Given this list of marker genes CALM3, PPP3CC, PPP3R1, CALM2, TFEB, PPP3R2, MCOLN1, CALM1, PPP3CA, PPP3CB, here is a description of the gene set: Human Gene Set: KEGG_MEDICUS_REFERENCE_LYSOSOMAL_CA2_RELEASE Lysosomal Ca2+ release. Pathway ID: N01644. Pathway type: Reference. Pathway class: nt06528 Calcium signaling. Pathway Definition from KEGG: PI(3.5)P2 -> MCOLN1 -> Ca2+(cyto) -> CALM == CN -> TFEB studied in species Homo sapiens